Given this list of marker genes Hemgn, Atxn7l3 (NCBI Gene Id 217218), Zfp609, Srgap2, Rai1, Mapk4, Ccl22, Hand1, Tktl1, Hoxa2, Sinhcaf, Vsig10l, Map1b, Hif3a, Myoz3, Ywhab, Tbc1d10b, Arl14epl, Gpr25, Slc6a4, Ptrhd1, Ptk2b, Bltp3a, Abcb7, Sp6, Mark2, Pigt, Ndst2, Cxcl13, Iglon5, Klhl35, Cdc42, Usp1, Mrpl1, Amot, Dgka, Ino80d, Nrbp1, Zfyve1 (zinc finger, FYVE domain containing 1), Rhobtb2, Pof1b, Mrpl50, Tpmt, Slc1a2, Sptan1 (NCBI Gene Id 76356), Syt7, Epb41l1, Tspyl2, Snph, Chd3, Lsm1, Adipor2, Rbm18, Gnao1, Lyz2, Vamp2, Prrc2a (proline-rich coiled-coil 2A), Aqp6, Arl13a (ADP-ribosylation factor-like 13A), Zdhhc9, Adam19, 1600012H06Rik (NCBI Gene Id 67912), Nr2f2, Pxmp4, Slc16a2, Galnt6, Rab39b, Cldn34c1, Hes3, Papln, Afap1, St14, Lpcat3, Pacsin1, Rfx7, Ptprg, Ipo8, Ucn3, here is a description of the gene set: studied in species Mus musculus from publication Chen Y, Wang X (PMID 31504780) Mouse Gene Set: MIR_7058_5P Genes predicted to be targets of miRBase v22 microRNA mmu_miR_7058_5p in miRDB v6.0 with MirTarget v4 prediction scores > 80 (high confidence targets).